The following is a description of a gene set: Human Gene Set: HP_DISTAL_UPPER_LIMB_AMYOTROPHY Muscular atrophy of distal arm muscles. species: Homo sapiens Distal upper limb amyotrophy, and this is the list of marker genes: UBAP2L, RILPL1, SPG11 (SPG11 vesicle trafficking associated, spatacsin), GDAP1, TFG (NCBI Gene Id 50989), MPV17, DCTN1, FLNC, NGLY1, TIA1, RYR1, MATR3, PLOD3, MORC2, HINT1, SPTLC1, CPLANE1, NOTCH2NLC, KANSL1, GNB4, HARS1, KLHL9, WARS1, FXN, MPZ, LRP12, LMNA, MARS1, TIMM8A, SLC52A3, CEP126, DYSF, PRX, GBF1, ALS2, TNR, NEB, SCO2, ACTA1, SLC25A21, INF2, ITPR3, TRPV4, NEFL, HSPB3, SLC5A6, KIF1A, FBLN5, IDUA (alpha-L-iduronidase), PDK3, GARS1, CADM3, JAG1, GJB1, ADAMTS15, BSCL2, PMP22, CHRNA1, SVBP, TRIM2, GIPC1, LDB3, VCP, RTN2, SLC39A13, SLC12A6, REEP1, SQSTM1, COMP, CAV3, CHCHD10